The following is a description of a gene set: Mouse Gene Set: GOBP_MAINTENANCE_OF_SISTER_CHROMATID_COHESION The process in which the association between sister chromatids of a replicated chromosome is maintained as chromosomes condense, attach to the spindle in a bipolar orientation, and congress to the metaphase plate. species: Mus musculus, and this is the list of marker genes: Slf1, Naa10, Nsmce2, Nipbl, Macroh2a1, Dscc1, Tnks (tankyrase, TRF1-interacting ankyrin-related ADP-ribose polymerase), Rb1, Mau2, Bub1 (NCBI Gene Id 99145), Slf2, Sgo2a, Smc5, Atrx